The following is a description of a gene set: A characteristic appearance resulting from defective ossification of craniofacial bones. Human Gene Set: HP_CRANIOFACIAL_DYSOSTOSIS studied in species Homo sapiens Craniofacial dysostosis, and this is the list of marker genes: MSX2 (msh homeobox 2), ALX4, EDNRA, IL11RA, RPS26, EFTUD2, POLR1C, FGFR2, SLC25A24